Given this list of marker genes H2-K1 (NCBI Gene Id 56628), Lin7c, Rimbp2, Mgst2, Soat1, Cts6, Xdh, Fam177a, Ppp1r3e, Akr1e1, C1qb, Rpgrip1, Rptoros, Vegfa, Prdx2, Hs6st1, Gprc5b, Efhd2, Cd300ld, Aldoc, F10, Hspa1b, Pkdcc, Fam241a, Pdxdc1, Bnip3, Arg1, Tulp4, Rgcc, Hilpda, Tmem267, Cytip, Snhg6, Ak4, Hspa1a, H2-D1, Pink1 (PTEN induced putative kinase 1), Gask1b, Cd5l, Tjp2, Procr, Qrich1, Chil3, Sh2b2, Znf41-ps, Ero1a, Uchl1, Ahnak2, Ctsk, Mcoln3, Rras2, Cblb, Ptger2, ENSMUSG00000143161, Myo1f, Thbs1, F7, Igf2r, Col20a1, Egln3, Lbp, Ankrd37, Atp6v0d2, Slc2a1, Il18bp, C1qtnf12, Wfdc17, 4833420G17Rik, Ighm, Scd2, Arsk, Tlr1, Flrt2, Cript, Adam8, Mfge8, Fblim1, Padi4, Fam199x, Cd300c2, Itgb3, Atg4d, Ang, Lrrc27, Gdf15 (growth differentiation factor 15), H2-Q5, Cd24a (NCBI Gene Id 12484), Bst1 (NCBI Gene Id 269647), C1qc, here is a description of the gene set: In addition to the directly mutagenic effects of energy deposition in DNA, ionizing radiation is associated with a variety of untargeted and delayed effects that result in ongoing bone marrow damage. Delayed effects are genotype dependent with CBA/Ca mice, but not C57BL/6 mice, susceptible to the induction of damage and also radiation-induced acute myeloid leukemia. Because macrophages are a potential source of ongoing damaging signals, we have determined their gene expression profiles and we show that bone marrow-derived macrophages show widely different intrinsic expression patterns. The profiles classify macrophages derived from CBA/Ca mice as M1-like (pro-inflammatory) and those from C57BL/6 mice as M2-like (anti-inflammatory); measurements of NOS2 and arginase activity in normal bone marrow macrophages confirm these findings. After irradiation in vivo, but not in vitro, C57BL/6 macrophages show a reduction in NOS2 and an increase in arginase activities, indicating a further M2 response, whereas CBA/Ca macrophages retain an M1 phenotype. Activation of specific signal transducer and activator of transcription signaling pathways in irradiated hemopoietic tissues supports these observations. The data indicate that macrophage activation is not a direct effect of radiation but a tissue response, secondary to the initial radiation exposure, and have important implications for understanding genotype-dependent responses and the mechanisms of the hemotoxic and leukemogenic consequences of radiation exposure. Down-regulated genes distinguishing between M1 (pro-inflammatory) and M2 (anti-inflammatory) macrophage subtypes. from publication Coates PJ, Rundle JK, Lorimore SA, Wright EG (PMID 18199539) species: Mus musculus Mouse Gene Set: COATES_MACROPHAGE_M1_VS_M2_DN